The following is a description of a gene set: Mouse Gene Set: MIR_3100_5P species: Mus musculus Genes predicted to be targets of miRBase v22 microRNA mmu_miR_3100_5p in miRDB v6.0 with MirTarget v4 prediction scores > 80 (high confidence targets). from publication Chen Y, Wang X (PMID 31504780), and this is the list of marker genes: Pacs2, Chd9, Ugt1a5, Grid1, Sptlc3, Prnd, Aqp6, Pdgfra, Nkain3, Tmem106b, Xcl1, Ugt1a7c (NCBI Gene Id 394432), Sox13, Cadm1, Ugt1a6b, Sv2c, Ifnar1, Chmp1b2, Zmat2, Ccdc22, Epb41l4a, Rabgef1, Rbbp7, Zfyve1, Dnah17, Abca12, Myocos, Ugt1a6a, Ggt7, Golga7b, Tox (thymocyte selection-associated high mobility group box), Casp2, Cnbp, Hbb-bs, Foxp4, Slc34a2, Ugt1a2, Arfgef3, Rngtt, Bak1, Calhm4, Zmynd11, Cav2, Ablim1, Tmem200c, Tgoln1, 9930111J21Rik2, Tnks2, Hspa1l, Birc3, N4bp3, Bmp2, Rfpl4, Odad3, Ccdc9, Syn3, Pmm1, Icam1, Adat1, Tmem18, Faf1, Pigk, Fzd5, Selenot, Tsc1, Gprasp2, C1galt1, Pramel3d, Clock, Ppp2r3d, Myorg, Cyp2s1, Lactb, Gtf3c2, Mob3b, Mgat3, Bend4, Ercc6l2, Ric3, Mbnl3, Spred1, Pnma1, Plekha5, Gpr179, Ugt1a10, Epgn, Ugt1a1 (NCBI Gene Id 394436), Eml3, Slc16a2, Rab11fip2, Lmod1 (leiomodin 1 (smooth muscle)), Syvn1, Prn, Arhgap44, Kel, Mfsd6, Pex5l, Sf3b3, Gata6, Ugt1a9, Dclre1c